The following is a description of a gene set: Shortening of all phalanges of the toes Human Gene Set: HP_SHORTENING_OF_ALL_PHALANGES_OF_THE_TOES studied in species Homo sapiens Developmental hypoplasia (shortening) of all phalanges of the foot., and this is the list of marker genes: ARSL, FIG4, KCNH1, NOG, TRPV4, SOX9, PIGF, VAC14